Given this list of marker genes CDC42EP3, KLHL41, PPL, VAMP8, FUCA1, PDLIM3, RARRES2, WIF1, OXTR, ALDH1A1, INA, ASS1, here is a description of the gene set: studied in species Homo sapiens from publication Morosetti R, Mirabella M, Gliubizzi C, Broccolini A, Sancricca C, Pescatori M, Gidaro T, Tasca G, Frusciante R, Tonali PA, Cossu G, Ricci E (PMID 17761758) Facioscapulohumeral muscular dystrophy (FSHD) is the third most frequent inherited muscle disease. Because in FSHD patients the coexistence of affected and unaffected muscles is common, myoblasts expanded from unaffected FSHD muscles have been proposed as suitable tools for autologous cell transplantation. Mesoangioblasts are a new class of adult stem cells of mesodermal origin, potentially useful for the treatment of primitive myopathies of different etiology. Here, we report the isolation and characterization of mesoangioblasts from FSHD muscle biopsies and describe morphology, proliferation, and differentiation abilities of both mesoangioblasts and myoblasts derived from various affected and unaffected muscles of nine representative FSHD patients. We demonstrate that mesoangioblasts can be efficiently isolated from FSHD muscle biopsies and expanded to an amount of cells necessary to transplant into an adult patient. Proliferating mesoangioblasts from all muscles examined did not differ from controls in terms of morphology, phenotype, proliferation rate, or clonogenicity. However, their differentiation ability into skeletal muscle was variably impaired, and this defect correlated with the overall disease severity and the degree of histopathologic abnormalities of the muscle of origin. A remarkable differentiation defect was observed in mesoangioblasts from all mildly to severely affected FSHD muscles, whereas mesoangioblasts from morphologically normal muscles showed no myogenic differentiation block. Our study could open the way to cell therapy for FSHD patients to limit muscle damage in vivo through the use of autologous mesoangioblasts capable of reaching damaged muscles and engrafting into them, without requiring immune suppression or genetic correction in vitro. Disclosure of potential conflicts of interest is found at the end of this article. Human Gene Set: MOROSETTI_FACIOSCAPULOHUMERAL_MUSCULAR_DISTROPHY_DN Genes down-regulated in FSHD (facioscapulohumeral muscular dystrophy) mesoangioblasts.